Given this list of marker genes ZNF131, POLG, SHMT2 (NCBI Gene Id 6472), SEC24D, P2RX4, N4BP2L2-IT2, INPP5J, EEF1B2, XPNPEP1, PTPRT, OGA, ACTR1A, ADORA2A, CFLAR, RELB (RELB proto-oncogene, NF-kB subunit), LAD1, TFAP2C, SNX19, DDX52, SCARF1, AUTS2, MARS1, SRGAP2, TAF6, CYLD, GGH, NUP188, DESI1, ZMYND11, TNPO1, NPAT, CXCL1, DMTN, RBP4, RBP1, LSM1, TP53BP2, PDE4DIP, CCL5, NECAP1 (NECAP endocytosis associated 1), VCAM1, MTSS1, NFKB1 (nuclear factor kappa B subunit 1), SLC18A3, GADD45G (growth arrest and DNA damage inducible gamma), RPL24, FSCN1, HLA-DOB, PLCB3, LAG3, GYPC (glycophorin C (Gerbich blood group)), MARCKSL1, RABGGTB, POLR3C, DDX6, TRAF1, SEPTIN11, HMGA1, SRP72, RPL23, CSF2RA, STAT4, IL10RA, ATF5, TUG1, TNFAIP3, CXCL11, PCDHB17P, CCL3, NFKB2, SASH1, TNFRSF4, IMPDH2, GLS, GSN, ANPEP, TSR1, MGLL, PLAGL2, RPGR, CSRP3, SCG5, IL1B, NDC80, G0S2, BAG1, LIMS1, ITCH, SELL, CD247, ITM2A, SLC16A3, SDC4, RPL27A, PSMD1, ATF3, ATP5MG, CACNB4, RPS25, SSPN, IL15RA, EZH2, ZKSCAN1, PSMA1, MACF1, PSPH, USP13, BCKDK, UAP1, SERPINE1, ZNF804A, LIN7A, THBS1, ILK, NOTCH3, SNX29, TAF1B, LAMP3, CDC42EP2, PIK3C3, GBP1, LMO3, EHD1, GCNT1, RPL4, TNF (NCBI Gene Id 7124), IDS, PIR, TNIP1, H1-0, MCCC2, TUT4, JUNB, VCP, CCR5, CFB, CYP2B7P, EIF3A, RPL37, SMC2, RSRC2, ALCAM, CD40, KCNJ15, NSA2, HIP1, PRPF3, SMARCE1, SRSF2, HCK, CD80, ICOSLG, NRAS, SERPINB9, FABP4, BCAR3, CD83, H2AC13, PDE8B, LAMA3, ST18, RNF11, CCL4, MARK3, FABP5, ARL4C, VOPP1, GP1BA, EXOC3, EPHB4, TXNL4A, LSS, AGFG1, ULK2, TNFAIP2, SLC7A5, PRPF19, BRD3OS, COQ7, GEM, MN1, NDUFV1-DT, MIR22HG, DNAJB5, GPKOW, EIF4H, ACVR2A, NFKBIA, MT2A, ITPA, NQO1, ERP44, SRSF10, RPL36A, NEMP1, UBE3C (NCBI Gene Id 9690), here is a description of the gene set: Human Gene Set: GSE19401_UNSTIM_VS_RETINOIC_ACID_STIM_FOLLICULAR_DC_DN from publication Suzuki K, Maruya M, Kawamoto S, Sitnik K, Kitamura H, Agace WW, Fagarasan S (PMID 20643338) studied in species Homo sapiens Genes down-regulated in the in vitro follicular dendritic cells from peripheral lymph nodes: non-stimulated versus tretinoin (96h). Germinal centers (GCs) are clusters of activated B cells built on stromal cells known as follicular dendritic cells (FDCs). In the Peyer’s patches (PPs), GCs are chronically induced by bacteria and are the major sites for generation of gut IgA immune responses. Whether FDCs directly contribute to the IgA production in PP GCs is unknown. To investigate the role FDCs in gut immune system, we examined comprehensive gene profiles of FDCs purified from PPs or perypheral lymph nodes (pLNs) with or without immunization. We also tried to reconstitute the PP FDC signature in vitro by pulsed or continuous stimulation of pLN FDCs through TLRs, RARs or simultaneously through TLRs and RARs.